Given this list of marker genes GGT7, HAGH, SLC7A11, GGT6, NFE2L2, GGT5, GGT1, MGST2, SLC1A2, GCLC, CHAC2, CHAC1, AASDH, GSS, BDH2, SLC1A1, GCLM, GGT3P, here is a description of the gene set: Human Gene Set: GOBP_NONRIBOSOMAL_PEPTIDE_BIOSYNTHETIC_PROCESS species: Homo sapiens The biosynthetic process in which peptide bond formation occurs in the absence of the translational machinery. Examples include the synthesis of antibiotic peptides, and glutathione.